Given this list of marker genes Fancd2, Fcrl5, Majin, Chfr, Gm2030, Ly6k, Rbp4, Zmynd12, Pum1, Ddx4, Zwint, Gm20820, Ovgp1, T, Adad2 (NCBI Gene Id 75773), Foxc1, Jag2, Cfap70, Hormad2, Dkkl1, Cxcl12, Hoxa9, Eqtn, Foxo3, Syce3, Trpc7, Klf17, Dnhd1, Nek1, Tbpl1 (TATA box binding protein-like 1), Gm1140, Ash1l, Ptgdr2 (NCBI Gene Id 14764), Pde3a, Hsf2bp, Adamts16, Ccnb3, Cfap65, Rln1, Dhh, Msx1, Tnk2, Tdrp, Igf1r, Prss42, Bbs4, Klc3, Arid4a, Scmh1, Ankle1, Actl7a, Ska1, Mgat4d, Nsun2, Ift56, Spo11, Acvr2a, Ppp2ca, Dpy19l2, Clasp2 (NCBI Gene Id 97514), Oog1, Mmp2, Insl6, Nobox, Phc2, Oosp2, Vdac3, Cyp26b1, Ube2q1, Tarbp2 (NCBI Gene Id 21357), Ccdc42, Ssty1, Ift27, Iho1, Wdr48, Rgn, Mael, Insr, Ddb1, Spaca4, Cfap119, Syde1, Pou4f2, Pln, Dnd1, Nup210l, Mir449a, Spata32, Gm21627, Itga3, Wnt3, Stag2, Stra8 (NCBI Gene Id 20899), Dld, Sox17, Etv6, Mcm7, Septin2, Rec8, Sly, Arid4b, Stat3, Cacna1h, Hspa2, Nppc, Gm5169, Spag4, Cdc25b, Foxj2, Iqcn, Pygo2, Kdm3a, Btg1, Rsph14, Cnr1, Dnaaf3, Cenps, Kitl, Dcaf17, Gm29554, Prnd, Foxj3, Hadh, Celf1, Sun1, Mtor, Spata33, Mir449c, Ddx3x, Ggn, Efcab9, Slc26a6, Tnp2, Ska2, Acsbg2, Aff4, Gm29276, Cabs1, Shbg, Mir449b, Jam3, Brdt, Rps6, Six5, Glra1, Msh2, Ak7, Ggnbp1, Fetub, Ttk, Calca, Gorasp2, Sox9, Ica1l, Kit, Eif2s3y, Sycp1, Lgr5, Pdcl2, Siah1a, Pla2g4a, Pttg1, Dnah1, Ntrk1, Catspere1, Ccna1, Sebox, Osm, Boll, Zdbf2, Upf3a, Izumo3, Tex14, Atp2b4, Gm21996, Espl1, Cct4, Spaca1, Diaph2, 3830403N18Rik, Gamt, Rb1, Dzip1, Paqr8, Cfap52, Parp11, Cntrl, Septin4, Fam170b, Plb1, Yif1b, Brme1, Agfg2, Herc2, Cdkn1c, Ddias, Gpx4, Bmal1, Spink13, Pcsk4, Slc22a14, Prss21, Gpr3, Usp42, Smc3, Rgs2, Pdilt, Dhx36, Yy1, Racgap1, Tle3, Wee2, Scaper, Arrdc5, Tssk1, Ppp3r2, Ctdnep1, Tubgcp6, Tgfb1, Zfp830, Astl, Hmga2, Spata25, Smcp, Nodal, Ccdc38, Dcst2, Plcb1, Mcm3, Ct55, Akt1, Gm773, Zfp541, Cenpx, Adam7, Wdr77, Rpa1, Celf3, Tnfaip6, Prkg1, Pla2g3, Sohlh2, Aldoa, Ccno (NCBI Gene Id 97901), Zmiz1, Bax, Calr (calreticulin), Fzr1, Adam26a, Tyro3, Stag3 (STAG3 cohesin complex component, NCBI Gene Id 50878), M1ap, Ncapd2, Ccnb1, Spire2, Spata31 (spermatogenesis associated 31), Katnal1, Mus81, Ccin, Rbx1, Stk33, Ccr6, Hvcn1, Fscn3, Piwil4, Plcz1, Gpr149, Ndc1, Insl3, Mkks, Foxl2, Pmis2, Birc5, Paip2, Sec23ip, Npr2, Fancl, Edn2, Krt9, Adig, Prmt7, Acox1, Spdya (speedy/RINGO cell cycle regulator family, member A), Zscan21, H1f6, Zar1l, H3f3b, Nicol1, Spem1, B4galnt1, Hoxd9, Cd9, Aurka, Tubgcp3, H1f1, Klhl10, Rad1, Gm29866 (predicted gene, 29866), Fancf, Fancm, Rbm7, Tesk2, Neurl4, Tubg1, Xlr3a, Htt, Stxbp1, Sohlh1, Pfn4, Fam170a, Odf1, Catsperg2, Nos3, Nbn, Nkapl, Gja1, Mdk, Spata46, Catsper3, Cfap54, Morc2b, Antxr2, Pla2g10, Redic1, Gli1, Rad50, Fam209, Gm21865, Gtsf1, Gm28576, Bnc1, Piwil1, Vgf, Gm20736, Camk2b, H2ax, Pcyt1b, Ubr2, 1700013H16Rik, Khdrbs1, Trp53, Spata20, Izumo1r, Tubgcp4, Gm20870, Tssk4, Nectin2, Rpl10l, Bub3, Tssk3, Ddx3y, Usp26, Spata22 (spermatogenesis associated 22), Mfge8, Styx, Spag6l, Adam5, Rhbdd1, BC005624 (NCBI Gene Id 227707), Nup62, Tmprss12, Ggnbp2, Map7 (microtubule-associated protein 7), Slc9b1, Irag2, Mos, Larp7, Gm14525, Pms2 (PMS1 homolog2, mismatch repair system component), Ttll3, Txndc8, Stk35, Rnf17, Syne1, Zfp39, Col6a1, Ube2j1, Itgav, Fst, Kmt2c, Dydc1, Pias1, Tssk5, Psme4, Dnmt3l (DNA methyltransferase 3-like), Cfap43, Plekha1, Hsf5, Ap3b1, Crem, Fignl1, Tle6, Fancc, Hpgd, Ttc12, Ythdc2, Mcm6, Ndn, Aspm, Spata9, Tssk2, Tsnaxip1, Mfsd14a, Zan, Sbf1, Atp1a4, Abhd2, Sun5, Gm21294, Pax5, Clock, Ccdc63, Garin5a, Lepr, Meiob, Meikin, Lgr4, Clic4, Eme1, Rbx1-ps, Slxl1, Stx2 (syntaxin 2), Atn1, Cct8, Kmt2d, Tmf1, Kcnq1ot1, Sstr3, H1f9, Btbd18, Shb, Ccnyl1, Bbs1, Tug1, Spam1, Zc3h14, Alms1, Cdc20, Cabcoco1, Cntln, Msh6, Piwil2, Slc4a2, Stau2, Rbm46, Mlh1, Atrx, Mei4, Ctnnb1, Rad51 (NCBI Gene Id 99282), Adam18, Setx, Ift25, Semg1, Zglp1, Plat, Igf1, Cfap58, Hus1, Cct7, Chd5, Mapk1ip1, Rmi1, Odf4, Fshb, Bcas2, Crkl, Chn2, Dmrt1, Pik3ca, Rab3a, Cylc1 (cylicin, basic protein of sperm head cytoskeleton 1), Dnmt3a, Park7, Usp17le, Numa1, H3f4, Bmp8b, Fsip1, Msh5, Ubap2l, Tial1, Xlr5c, Limk2, Smad1 (SMAD family member 1), Rnf151, Gnas, Dnmt3b, Spaca3, Txndc2, Edn1, Catsperz, Actl9, Tdrkh, Pgm3, Terf1, Neurl1a, Glipr1l3, Zfp41, Catspere2, Bend2, Trim36, Gopc, Kmt2b, Rnf2 (ring finger protein 2), Sirt7, Cfap206, Ccdc33 (coiled-coil domain containing 33), Kdm1b, Slc9a8, Paqr7, Prdm9, Mast2, Lyzl6, Rad51c, Lztfl1, Syt6, Bltp1, Gmnc, Rsph6a, Folr2, Ncaph2, Mecp2, Crtap, Bmpr1b, Ptgds (prostaglandin D2 synthase (brain)), Ncaph, Ccdc34 (NCBI Gene Id 99030), Smc4, Rps6ka2, Mir34b, Inpp5b, Asz1, Mcm2, Spag1, Sgo2a, Mov10l1, Pabpc1l, Crisp1, Herc4, Mcm5, Unc13b, Galntl5, Prr19, Cfap69, Il1a, Dnaja1, Pde4d, Gm10488, Rai14, Pacrg, Rad51ap1, Eif4h (NCBI Gene Id 52314), Ggt1, Sfmbt1, Spin1, Cep63, Prss55, Smchd1, Cadm1 (cell adhesion molecule 1), Xlr3b, Fmn2, Gas2 (NCBI Gene Id 14453), Tcp11, Folr1 (NCBI Gene Id 14275), Mybl1, H1f7, Lrrk2, Pdik1l, Serpina5, Pde5a, Shoc1, Kctd19, Ube3a, Tcp11x2, Catsper2, Terb2, Src, Dmxl2, Hps1, Catsper1 (NCBI Gene Id 225865), Glipr2, Ccdc136, Immp2l, Zscan2, D1Pas1, Crisp2, Cd46, Nell2, Wnt5a, Hoxa10, H19, Cpeb1 (cytoplasmic polyadenylation element binding protein 1), Mroh2b, Washc5, Pank2, Ttll1, Actr3, Pnma5, Llcfc1, Snu13, Tsnax, Haspin, Crisp3, Hook1 (NCBI Gene Id 77963), Rims1, Tlk2, Ppp3cc, Terb1, Ar, Stau1, Ttll8, Tspan8, Gm28102, Ehmt2, Garin4, Axdnd1, Cfap57 (NCBI Gene Id 77131), Spin2c, Rab1a, Magoh, Ing2, Pkdrej, Spatc1l, Dmrtc2, Slc25a31, Sun2, Clgn, Prok2, Akap4, Rnf114, Bcap31, Ptx3, Top6bl, Mlh3, Myh9, Tex11, Adam24, Xlr, Lin28a, Wt1, Stk11, Rimbp3, Zar1, Prdm1, Skil, Rnase9, Nuf2, Fer, Zmynd15, Adad1, Zp2, Orc4, Acrbp, Aurkc, Spag8, Zpbp2, Mcidas, Pafah1b3, Hyal3, Lhfpl2, Hexb, Gm28870, Dusp1, Pygo1, Gm28961, Prm2, Tssk6, Spata16, Ube2b, Prss37, Hoxa11, Calr3, Spink2, Gmcl1, Bcl2, Kcnu1, Tm9sf5, Zfp42, Prm3, Zfp318, Hspa1b, Iqub, Ooep, Hoxd11, Pkmyt1, Nos2, Sass6, Shcbp1l, Leat1, Bcl2l11, Asb17, Frey1, Gal3st1, B4galt1, Adamts2, Foxa3, Gm10230, Gm21095, Etv5, Prm1, Inhbb, Smad5, Fxr1, Rpl39l, Cfap47, Ednra, Plk1, Tmem203, Tppp2, Dpcd, Zp1, Slx, Zfp296, Ereg, Cylc2, Wipf3, Spink1, Catsperd, Meioc, Armc2, Agt, Tpgs1, Ints13, Gm5935, Exo1, Ctcf, Hoxd10, Mst1, Fbxo43, Hormad1, Glipr1 (GLI pathogenesis related 1), Duox2, Trp63, Cnbd2, Sry, Prdm14, Spata2, Kdm5b, Kdm2b, Prss43, Shisa6, Airn, Nkd1, Ccnb2, Msx2, Mycn, Xlr4a, Slc9c1, Ccdc87 (coiled-coil domain containing 87), Mns1, Sirt1, Tubgcp2, Pnldc1, Nanos3, Lcn6, Syce2, Gsk3b, Spmip6, Cep128, Kat5, Trpc3, 4930451I11Rik, Cdc25a (NCBI Gene Id 52289), Itpr1, Mcm8, Lrrc8a, Ihh, Ovch2, Nrip1, Syce1, Taf7l, Tex12, Defb1, Spaca7, Rnf212b, Trpc2 (transient receptor potential cation channel, subfamily C, member 2), Garin3, Taf4b, Acvr1, Cul4a, Tut7, Ros1, Bsph1, Cast, Tesk1, Cldn11, Bsg, Creb3l4, Strbp, Mcmdc2, Galnt3, Kdm5a, Ybx3, Axl, Gm28510, Ercc4, Atp8b3, Oca2, Slc26a8, Apob, Cfap91, Brca2, Meg3, Zbtb16, Wbp2nl, Cfap157, C2cd6, Sox3, Eed, Dedd, Zfp449, Suv39h2, Alkbh5, Slirp, Adam1a, Pafah1b2, Kash5, Meiosin, Wdr54, Sirt2, Tubg2, Mta2, Dcst1, Adcy10, Hrob, H2al2a, Tex19.1, Trim28, Spag17, Top2a, Wnt4, Spata6l, Drc1, Spata19, Ccne2, Gjb3, Klhdc3, Gm7958, Ptch1, Poc1a, Gm20824 (NCBI Gene Id 105247282), Ythdf2, Npm2, Tesmin, Fbxw11, Hmga1, Marf1, Catsperb, Vipas39 (VPS33B interacting protein, apical-basolateral polarity regulator, spe-39 homolog), Mkrn2, Nr6a1, Ddx25, Zp3r, Sox8, Adrm1, Septin14, Zfp148, Zcwpw1, Lrrc46, Mea1, Igf2r, Lfng, Selenof, Gm38999 (predicted gene, 38999), Syt8, Tgfbr1, Golga2, Tdrd5, Umodl1, Tmem95 (NCBI Gene Id 432576), Dicer1, Iftap, Tpst2, Mastl, Slc19a2, Mycbpap, Tdrd1, Sptbn4, Poc1b, Cib1, Xlr5a, Slc22a16, Hsf1, Tdrd9, Rad54b, Cxcr4, Selenop, Garin1b, Spin4, Ezhip, Cks2, Hoatz, Ankrd31, Pgr, Hspa1l, Bsph2, Slc26a3, Ctsl (cathepsin L), Ctcfl, Smc1b, Bbs2, Spa17, Adamts1, Mre11a, Psmd13, Cdk2, Incenp, Pmfbp1, Ppp2r1a, Armc3, Nectin3, Gm20817, Nphp1, Lhcgr, Ovol1, Dazap1, Lep, Lrriq1, Rhox8, Cfap221, Mas1, Gm2012, Zpbp, Spag6, Odf2, Spmap2, Spef2, Ghsr, Cox7b2 (cytochrome c oxidase subunit 7B2), Glipr1l1, Cct6a, Xist, Trip13, Osbp2, Tmem119, Il18, Akap9, Bscl2, Hfm1, Agfg1, Sstr1, Ift20, Adam2, Cit, Sos1, Bag6, Rsph1, Dmc1, Cimap1a (ciliary microtubule associated protein 1A), Septin7, Spire1, Iqcg, Garin1a, Utp14b, Rxfp2, Svs3a (seminal vesicle secretory protein 3A), Chtf18, Gdf9, Cfap53, Misfa, Tdrd12, Amh (NCBI Gene Id 11705), Hexa, Cdk16, Ptk2b, Topaz1, Sycp3, Btbd35f1, Sufu, Rnase10, Lypd4, Adam1b, Dnajb13, Glrb, Eme2, Cenpc1, Cep57, Rfx2, Smc2, Ybx2, Cenpe, Arhgap33os, Grb14, Ago4, Ccdc159, Bmp8a, Spaca5, Morn2, Top2b, Gm20890, Trim75, Slx4, Prkaca, Nlrp14, Ace, Rnf212, Cnot7, Fosl1, Hmgb2, Spata24, Iqcf1, Gata4, Patz1 (POZ (BTB) and AT hook containing zinc finger 1), Ccnb1ip1 (NCBI Gene Id 632913), Cct3, Mcm4, Fhad1, Adam25, Paqr5, Cdyl, Spesp1, Gja10, Oas1d, Csnk2a2, Nme8, Xlr3c, Cabyr, Spag16, Knl1, Tex19.2, Adcy3, Notch1, Hpgds, Gk2, Cip2a, Fsip2, Ccdc62, Septin1, Dlec1, Plcd4, Garin5b, Sox30, Armc12, Gm20843, Tsga8, Cfap44, Pebp1, Ptn, Glipr1l2, AU040320, Fndc3a, Gm6121, Hus1b, Herpud2, Fbxo5, Washc1, Kat8, Gsk3a, Bckdk, Pafah1b1, Tut4, Defb37, Vps54, Ropn1, Nr0b1, Rad18, Ttll5, Sgo1, Cntd1, Tslrn1, Spaca6, Tcp1, Slco4c1, Ropn1l, Msh4 (NCBI Gene Id 99856), Fbxo24, Tmem232, Xlr4c, Tbata, Prdx4, Afg2a, Nr5a2, Gnasas1 (NCBI Gene Id 56802), Hsf2 (heat shock factor 2), Zfp628, Mir34c, Bbof1, Bcl6, 1700102P08Rik, Zfp35, Pgam2 (NCBI Gene Id 56012), Snrpa1, Rsph9, Jam2, Gsr, Zfx, Tnp1, Adam3, Bmp4, Nek2, Septin6, Zp3, Mapk15, Ndc80, Itgb1, Vps13b, Svs3b, Tsx, Spocd1, Crisp4, S100a11, Exd1, Pithd1, Smc1a, Cyp51, Adgb, Brip1, Hyal5, Gm21117 (NCBI Gene Id 108168594), Cetn2, Fanca, Ncapd3, Pld6, Nanos2, Mcm9, Rad23b, Zfp37, Bik (BCL2-interacting killer), Xrn2, Cct2, Xlr4b, Cxadr, Ift81, Lif, Gm5168, Tex101 (NCBI Gene Id 75446), Sycp2, Ssh2, Mei1, Garin2, Sod1, Iqch, Adcyap1r1 (adenylate cyclase activating polypeptide 1 receptor 1), Smad4, Cdc25c, H2bc1, Uchl1, Ccne1, Prss44, Fkbp6, Nanos1, Cep131, Spinkl, Mmp19, Gnpda1, Spmip7, Mki67, Lyzl4, Rara, Eif4g3, Cfap97d1, Tbc1d21, Eif2s2 (eukaryotic translation initiation factor 2 subunit 2 beta), Afp, Rad21l, Zfp57, H3f3a, Morc1, Aaas, 1700028K03Rik, Spem3, Acr, Lamp1, Sppl2c, Meig1 (NCBI Gene Id 17267), Rabl2, Odad3, Nr2f2, Trpc6, Txnrd3, Klk14, H2aj, Ddx20, Tex15, Cct5, Catsper4, Ankrd49, Vdac2, Rad54l, Gm21858, 4930447C04Rik, Gm1993, Drc7, Rad51d, Pten, Psma8, Dnali1, Qki, Cecr2 (NCBI Gene Id 76549), Ppp1cc, Figla, Gm21760, Ercc1, Gm28919, Nme5, Lrguk (leucine-rich repeats and guanylate kinase domain containing), Mettl14, Izumo1, Xrn1, Kif18a, Rec114, Tdrd7, Psmc3ip, Golga3, Rsph3b, Prkacb, Rbbp8, Nr2c2, Gm5934, Cftr, Topbp1, Pxt1 (peroxisomal, testis specific 1), Inhba, Tsix, Gm4297, Tuba8 (NCBI Gene Id 53857), Fancg, Atm, Spata6, Mertk, Angpt2, Pmp22, Rps6kb1, Arsa, Nlrp5, Mnd1, Tbc1d20, Ska3 (spindle and kinetochore associated complex subunit 3), Tubgcp5 (NCBI Gene Id 259278), Mamld1, Adam32, Ythdc1, Xlr5b, Cfap61, H1f8, Epc1, Ift88, Sstr2, Rnf8, Atat1, Gm20911, Mettl3, Bcl2l1, Syce1l, Tdrd6 (tudor domain containing 6), Tmem81, Ubb, Rspo1, Dazl, Actr2, Lsm14b, Dcaf13, Zfy2, Sgpl1, Fshr, Ttc21a, Ccdc146, here is a description of the gene set: A type of reproduction that combines the genetic material of two gametes (such as a sperm or egg cell or fungal spores). The gametes have an haploid genome (with a single set of chromosomes, the product of a meiotic division) and combines with one another to produce a zygote (diploid). studied in species Mus musculus Mouse Gene Set: GOBP_SEXUAL_REPRODUCTION